Given this list of marker genes GABRB3, HTR3A, CHRNE, CHRM1, LY6E, CHRNA7, GABRB1, GRM5, HTR3E, LY6H, GRIN3B, GRIA3, GRIN2B, CHRFAM7A, GABRA2, GRIN3A, GRID1, SPDYE11, LYNX1, HTR3D, HTR3C, GABRA5, CHRNA4, GRIN2C, CHRM4, PSCA, CHRNB1, LYPD6, PATE1, SLURP2, GRIK5, GLRA1, GRIK4, GABRA1, CHRM2, GRIA1, LY6G6D, ADRB1, CHRNA5, PATE4, GRIK3, CHRND, GRIN2D, KCTD16, GRID2, TMEM35A, LYPD1, GABRA3, GRIK1 (NCBI Gene Id 2897), CHRNA3, GABBR1, GRIN2A, GRM1, LY6S, GRIA4, GABRR2, GRIK2, GRIA2, CHRM5, CHRM3, CHRNB2, CDK5, DRD5, CHRNA6, CHRNA9, DRD2, GABRD, CHRNA2, GABRG3, DRD3, SLURP1, CHRNB4, GABRB2, GLRB, CHRNA10, GABRG2, CHRNA1, LYPD6B, GLRA2, GABRA6, HTR3B, CHRNG, ANXA9, GABRA4, DRD1, DRD4, APP, CHRNB3, here is a description of the gene set: species: Homo sapiens Neurotransmitter receptor activity occurring in the postsynaptic membrane during synaptic transmission. Human Gene Set: GOMF_POSTSYNAPTIC_NEUROTRANSMITTER_RECEPTOR_ACTIVITY